The following is a description of a gene set: Human Gene Set: HP_HYPOPLASTIC_FEMALE_EXTERNAL_GENITALIA species: Homo sapiens Underdevelopment of part or all of the female external reproductive organs (which include the mons pubis, labia majora, labia minora, Bartholin glands, and clitoris). Hypoplastic female external genitalia, and this is the list of marker genes: FGFR2, POR (cytochrome p450 oxidoreductase), TWIST2, SNORD115-1, HDAC8, SMC3, SNORD116-1, ACTB, NXN, CDC6 (NCBI Gene Id 990), CDT1, SETBP1, PWRN1, GAD1, MAGEL2, CTCF, CHD7, IRF6, TBC1D20, SEMA3E, TAF6 (NCBI Gene Id 6878), DVL3, NPAP1, TP63, RAC3, UBE3B, ESR2, RAB18, WNT5A, PPP2R3C, MKRN3, RAB3GAP1, RAB3GAP2, RAD21, OCA2, SNRPN, FZD2, CCNQ, BRD4, GMNN, KAT6B, VAC14, PORCN, ROR2, DVL1, ORC1, ORC6, ECEL1, ORC4, CDC45, B3GLCT, SMC1A, SLC25A24, POC1A, PWAR1, SIM1, RIPK4, SMARCA2, FIG4, HERC2, NDN, NIPBL, SMCHD1, MOGS, HNRNPR (NCBI Gene Id 10236), AR, MAB21L1